The following is a description of a gene set: The process in which a precursor cell type acquires the specialized features of an immature B cell. Human Gene Set: GOBP_IMMATURE_B_CELL_DIFFERENTIATION studied in species Homo sapiens, and this is the list of marker genes: PRKDC, IGHM, ABL1, TNFSF13B, LAPTM5, SPIB, ATM, IRF2BP2, KIT, SPI1, RAG2, FNIP1 (NCBI Gene Id 96459), LRRC8A, RAG1, TRAF3IP2, SYVN1